Given this list of marker genes MT1B, MT1DP, DAXX (NCBI Gene Id 1616), CYBB, MT1E, ABCB6, HSF1, MT1F, MT1G, MT1A, SUMO1, HMOX1, MT4, MT1X, PPP5C, HESX1, MT3, SLC11A1, SOD1, CYP1A2 (cytochrome P450 family 1 subfamily A member 2), SLC39A8, MT1M, MT1HL1, MT2A, MT1H, CER1, here is a description of the gene set: Human Gene Set: GOBP_CELLULAR_RESPONSE_TO_CADMIUM_ION species: Homo sapiens Any process that results in a change in state or activity of a cell (in terms of movement, secretion, enzyme production, gene expression, etc.) as a result of a cadmium (Cd) ion stimulus.